Given this list of marker genes GBP1 (guanylate binding protein 1), ABHD4, IFIH1, DHX58, CDCP1, HSPB1, CPXM2, IFNB1, IFITM1 (interferon induced transmembrane protein 1), H2AC6, ABCA1, GBP2, VWA5A, BCAR1, SAMD9L, SERPINE1, CD276, CD52, PTGER1, OCSTAMP, LRRC77P, GPRC5C, PLEK (pleckstrin), IFI27, NEDD9, FRZB, IFIT3, IL1RN, BLK, PTGER4, AK5, SPATS2L, BATF2, EPSTI1, AVPR1A, COL6A3, CLDN16, IFIT2, IFIT5, NCOA7, IFIT1, HES4, ATP8A2, IFI44L, GATA3, RAMP1, MOXD1, EIF2AK2, CELA2B, SPRY4, SUCNR1, CMKLR1, DDX60, TMIGD3, STAT1, HDAC9, SPINK4, SAMD9, CPHL1P, PPP1R16B, RTP4, IFI35, BAMBI, LINC03088, ANGPTL6, SELP, CXCL10, CXCL11, HBEGF, SPP1, PROS1 (protein S), DGKI, GJA5, TMEM221, IRF7, ARHGAP20, PDLIM4, MAP2, HPGD, HMCN1, LY6E, HERC5, LCK, SLFN5, RYR2 (NCBI Gene Id 6262), C1orf116, PRR5L, ID2, CYP1B1, TRIM25, IRAK2, BCL2A1, PLPP1 (NCBI Gene Id 94702), CD69, RNF213, VCL, ASAP2, ISG15 (NCBI Gene Id 9636), LAX1, BMF, FOXC2, EPHA2, RELB, KDR, IFI6, IFITM3, SP110, IL2RB, SHISA5, IRF9, USP18, DAPP1, SHFL, OAS2, GSN, IL24, KLHDC8A, RGS1, EGR3, XIRP1, RGS13, KCNA3, CCL4, PKDCC, MX1, GPR142, MYL9, ALOX12, ZNF683, SEPTIN5, H1-0, HPSE, TDRD7, LINC02454, CSMD3, TTC24, HEY1, SMAD6, FCMR, RAB27B, OAS3, PARP9, SLFN14, PDE3A, UBASH3B, PARP10, TUBAL3, CAV2, KALRN, ABCC3, SNPH, HERC6, WNT11, HELZ2, DTX3L, DDX60L, ENSG00000269954, DAB2, TNFSF18, SIGLEC9, ROR1, RIGI, GGTA1, ANKRD45, PITPNC1, ADAM12, KRT79 (NCBI Gene Id 338785), PDE9A, BST2, OASL, RDH10, LGALS3BP, LAMP3, CCL5, XAF1, PARP12 (poly(ADP-ribose) polymerase family member 12), SLC7A7 (solute carrier family 7 member 7), MTUS1, ARAP3, PLSCR1, IFI44, MX2, ISG20, SERPINI1, CR1L, OAS1, GBP5, RSAD2, AFAP1, FBXO6, here is a description of the gene set: Genes upregulated in short-term hematopoietic stem cells (CD34+,CD38_,CD45RA_,CD90_,CD49f_) upon overexpression of Sphingosine-1-Phosphate Receptor 3 (S1PR3) studied in species Homo sapiens Human Gene Set: XIE_ST_HSC_S1PR3_OE_UP Acute myeloid leukemia (AML) is a caricature of normal hematopoiesis driven from leukemia stem cells (LSC) that share some hematopoietic stem cell (HSC) programs including responsiveness to inflammatory signaling. Although inflammation dysregulates mature myeloid cells and influences stemness programs and lineage determination in HSCs by activating stress myelopoiesis, such roles in LSCs are poorly understood. Here, we show that S1PR3, a receptor for the bioactive lipid sphingosine-1-phosphate, is a central regulator that drives myeloid differentiation and activates inflammatory programs in both HSCs and LSCs. S1PR3-mediated inflammatory signatures varied in a continuum from primitive to mature myeloid states across cohorts of patients with AML, each with distinct phenotypic and clinical properties. S1PR3 was high in LSCs and blasts of mature myeloid samples with linkages to chemosensitivity, whereas S1PR3 activation in primitive samples promoted LSC differentiation leading to eradication. Our studies open new avenues for therapeutic target identification specific for each AML subset.<BR/>Significance: S1PR3 is a novel regulator of myeloid fate in normal hematopoiesis that is heterogeneously expressed in AML. S1PR3 marks a subset of less primitive AML cases with a distinct inflammatory signature and therefore has clinical implications as both a therapeutic target and a biomarker to distinguish primitive from mature AML. from publication Xie SZ, Kaufmann KB, Wang W, Chan-Seng-Yue M, Gan OI, Laurenti E, Garcia-Prat L, Takayanagi SI, Ng SWK, Xu C, Zeng AGX, Jin L, McLeod J, Wagenblast E, Mitchell A, Kennedy JA, Liu Q, Boutzen H, Kleinau M, Jargstorf J, Holmes G, Zhang Y, Voisin V, Bader GD, Wang JCY, Hannun YA, Luberto C, Schroeder T, Minden MD, Dick JE (PMID 33458693)